Given this list of marker genes UGT8, PLPP5, MTUS1, DNAJC9, KIAA0319L, LRPPRC, MGAT5, UBXN4, MOAP1, AK3, CRISPLD2, ACBD5, ATP6V1G2, NRDE2, WWTR1, PRUNE1, PCF11, JMJD8, LANCL2, ANKRD1, TMC6, SPG11, SH3GLB1, ZNF605, GALK1, CDCA4, TACC1, ZC3H12A, AMIGO1, PDCD11, RPS6KA4, U2AF1, HIPK1, N4BP1, SUPT7L, CRIP1, IVNS1ABP, TRMU (NCBI Gene Id 55687), ARAP3, RPS3, ZNF415, SLC12A8, NOL7, TBC1D16, TRIM33, PDLIM1, ARPP21, GRHL2, YRDC, CASP4LP, EFL1 (NCBI Gene Id 79631), here is a description of the gene set: Metastasis-related recurrence often occurs in hepatocellular carcinoma (HCC) patients who receive curative therapies. At present, it is challenging to identify patients with high risk of recurrence, which would warrant additional therapies. In this study, we sought to analyze a recently developed metastasis-related gene signature for its utility in predicting HCC survival, using 2 independent cohorts consisting of a total of 386 patients who received radical resection. Cohort 1 contained 247 predominantly HBV-positive cases analyzed with an Affymetrix platform, whereas cohort 2 contained 139 cases with mixed etiology analyzed with the NCI Oligo Set microarray platform. We employed a survival risk prediction algorithm with training, test, and independent cross-validation strategies and found that the gene signature is predictive of overall and disease-free survival. Importantly, risk was significantly predicted independently of clinical characteristics and microarray platform. In addition, survival prediction was successful in patients with early disease, such as small (<5 cm in diameter) and solitary tumors, and the signature predicted particularly well for early recurrence risk (<2 years), especially when combined with serum alpha fetoprotein or tumor staging. In conclusion, we have shown in 2 independent cohorts with mixed etiologies and ethnicity that the metastasis gene signature is a useful tool to predict HCC outcome, suggesting the general utility of this classifier. We recommend the use of this classifier as a molecular diagnostic test to assess the risk that an HCC patient will develop tumor relapse within 2 years after surgical resection, particularly for those with early-stage tumors and solitary presentation. species: Homo sapiens Human Gene Set: ROESSLER_LIVER_CANCER_METASTASIS_DN from publication Roessler S, Jia HL, Budhu A, Forgues M, Ye QH, Lee JS, Thorgeirsson SS, Sun Z, Tang ZY, Qin LX, Wang XW (PMID 21159642) Genes down-regulated in liver samples containing tumor thrombi in the major branches of the portal vein at surgery (PT) compared to those from metastasis-free HCC patients (PN) at the time of surgery and at follow-up.